Given this list of marker genes TNPO3, COL6A3, LRP12, TMEM43, PABPN1, MAP3K20, DES, CHCHD10, FHL1, DYSF, PLIN4, SQSTM1, COL12A1, SIL1, LMNA, HNRNPA1, PNPLA2, MYH7, ACTN2 (NCBI Gene Id 88), ANXA11, VCP, NEB, GIPC1, SMPX, HNRNPA2B1, COL6A2, HNRNPDL, TCAP, EMD, COL6A1, SYNE1, TTN, DNAJB6, ACTA1, DPM3, GGPS1 (NCBI Gene Id 9453), NEFH, MATR3, SMN1, MEGF10, RILPL1, GNE, ADSS1, NOTCH2NLC, SYNE2, TIA1, here is a description of the gene set: Presence of abnormal vacuoles (membrane-bound organelles) in the sarcolemma. On histological staining with hematoxylin and eosin, rimmed vacuoles are popcorn-like clear vacuoles with a densely blue rim. The vacuoles are often associated with cytoplasmic and occasionally intranuclear eosinophilic inclusions. Human Gene Set: HP_RIMMED_VACUOLES Rimmed vacuoles species: Homo sapiens